The following is a description of a gene set: Human Gene Set: HP_LUPUS_NEPHRITIS Lupus nephritis Lupus nephritis is a type of glomerulonephritis that constitutes one of the most severe organ manifestations of systemic lupus erythematosus. Lupus nephritis is subclassified in six distinct classes, that represent different manifestations and severities of renal involvement and guide the therapeutic management. studied in species Homo sapiens, and this is the list of marker genes: C4B, TNFAIP3, PDCD1 (NCBI Gene Id 56179), UBE2L3, IGHG1, FCGR3B, JAZF1, IRF5, TNFSF4, TLR7, CR2, IRAK1 (NCBI Gene Id 3654), PXK, DNASE1, PTPN22, TNIP1, DNASE1L3, IL10, BLK (NCBI Gene Id 84743), SPP1, TREX1, C4A, FCGR2A, ETS1, BANK1, KIAA0319L, STAT4, MECP2, HLA-DRB1, ITGAM, CTLA4, FCGR2B